Given this list of marker genes Ighv8-4, Msh2, C1rb, Ighv13-2, Parp3, Crp, Enpp1, Cd81, Ighv1-31, Myd88, Ighv14-4, Nod2, Iglc1, Il13ra2, Nfkbiz, Ighv1-34, Shld3, Il2, Ighv8-5, Ighv1-22, Bcl6, Ighv1-43, Ighv8-6, Il4ra, C2, Cd74, Ighv6-4, Ighv1-58, Ighm, 6030468B19Rik, Ighv1-5, Ighv11-1, Ighv2-3 (NCBI Gene Id 238412), Nectin2, Ighv1-42, Mlh1, BC037156, Serping1, Iglc2, Bcl10, Ighg1, Shld1, Card9, Ighv1-82, Rif1, Ighv1-67, Shld2, Fcrlb, Cfi, Ighv1-53, Cd40lg, Ighv1-80, Zp3r (zona pellucida 3 receptor), Ighv1-54, Ighv8-9, Ccr6, Fcgr1, Ighv14-1, H2-M3, Ighv3-6, Ighv1-16, Mad2l2, Igha, Tbx21, Csf2rb, Ercc1, Ighv5-6, Il9r, Tnf, Ighv1-78, Cr2, Ighv8-11, Fcer1g, Irf7, Csf2rb2, Rnf168, Ighv1-39, C4bp, Cd40, Ighv2-9, Rnf8, Cr1l, Ighv9-2, Ighv1-49 (immunoglobulin heavy variable 1-49), Ighv1-81, Susd4, Il4, Tcirg1, Ighv1-26, Icosl, Stat6, Ighg3, Ptpn6, Cd226, Ighv9-1, Lig4, Fcer2a, Ighv9-3, Ighv2-2, Fgl2, Ighv1-4, Zp3 (NCBI Gene Id 22788), Trem2, Fcer1a, Igll1, Cfh, Pou2f2, Ighv7-1, C1qc, Ighv2-6-8, Hc, Trex1, Gapt, Ighv1-64 (immunoglobulin heavy variable 1-64), Slc15a4, Ighv2-7, Il27ra, Ighv16-1, Cd46, C1s2 (NCBI Gene Id 317677), Ighv3-3, Ighv1-72 (NCBI Gene Id 619916), Gcnt3, Ighg2c, Ifng, Ighv6-7, Ighv11-2 (NCBI Gene Id 780818), C1qa, Ighd, Crlf2, C8b, C1qb, Cd28, Atad5, Foxj1, Ighv5-16, Il9, Ighv2-4, Ighv12-3, Exo1 (exonuclease 1), Ighv1-66, C1qbp, Ighv8-8, Ighv1-7, Ighv1-12, C8a, Ighv1-84, Trp53bp1, C9, Ighv1-47, Fcmr, Ighv2-9-1, Il2rb, Kmt5c, Ighv9-4, Ighv8-12, C3, Fcgr4, Ighv8-2, Nsd2, Cd55, Mir181b-2, Aplf, Iglc3, Ighv1-15 (NCBI Gene Id 629865), Traf3ip2, Ighv1-61, Ighv5-17, H2-Ea, Fcgr2b, Mbl2, Ighv1-63, Ptprc, C1rl, Paxip1, Gimap3 (GTPase, IMAP family member 3), Hpx (NCBI Gene Id 15458), Ighv5-9, Cd55b, C1ra, Ighv3-8, C1s1, Fas, Xrcc4, Ighv1-55, Ighv4-1, Ndfip1, Pms2, H2-T23, Ighv1-56, Exosc3, Ung, Hspd1, Tnfsf13, Mbl1, Batf, Ighv5-12-4, Xcl1, Ighv6-6, C4b, Ighv2-6, Ighv1-62-3, Ighv1-75, H2-DMa, Exosc6, Ighv1-77, Kmt5b, Foxp3, Ighv8-13, Ighv3-1, Ighg2b, Inpp5d, Ighv3-5, Ighv5-4, Ighv7-3, Clcf1, Ighv14-2, Swap70, Nbn, Masp2, Ighv6-3, Mir181b-1, Ighv3-4, Ighe, Btk, Gimap5 (GTPase, IMAP family member 5), Tnfsf4, Cd19, C8g, Ighv1-24 (immunoglobulin heavy variable V1-24), Ighv2-5, Ighv1-11, Ighv1-71 (immunoglobulin heavy variable 1-71), Ighv1-50, Ighv1-76, Bcl3, Ighv10-1, Prkcd, Lta, Tgfb1, Ighv6-5, Ighv5-12, Supt6, Ighv1-23, Ighv1-85, Pagr1a, Ighv10-3, Msh6, Sanbr, Pcyt1a, Cd70, Fcgr3, Ighv14-3, Pirb, Tfrc, Aicda, Hmces, here is a description of the gene set: Any process involved with the carrying out of an immune response by a B cell, through, for instance, the production of antibodies or cytokines, or antigen presentation to T cells. Mouse Gene Set: GOBP_B_CELL_MEDIATED_IMMUNITY species: Mus musculus